The following is a description of a gene set: from publication Rodwell GE, Sonu R, Zahn JM, Lund J, Wilhelmy J, Wang L, Xiao W, Mindrinos M, Crane E, Segal E, Myers BD, Brooks JD, Davis RW, Higgins J, Owen AB, Kim SK (PMID 15562319) Human Gene Set: RODWELL_AGING_KIDNEY_UP studied in species Homo sapiens In this study, we found genes that change expression in the cortex and the medulla of the kidney with age. Some of the genes whose transcripts increase in abundance with age are known to be specifically expressed in immune cells, suggesting that immune surveillance or inflammation increases with age. The age-regulated genes show a similar aging profile in the cortex and the medulla, suggesting a common underlying mechanism for aging. Expression profiles of these age-regulated genes mark not only age, but also the relative health and physiology of the kidney in older individuals. Finally, the set of aging-regulated kidney genes suggests specific mechanisms and pathways that may play a role in kidney degeneration with age. Genes whose expression increases with age in normal kidney., and this is the list of marker genes: PTPN22, MPEG1, ANTXR1, CD38, DOCK2, C7, ST8SIA4, IL4I1, DKK3, COL1A1, PCDHA9, TRAFD1, PGGHG, MGAT1, ASAP1 (NCBI Gene Id 56237), CHRNA3 (cholinergic receptor nicotinic alpha 3 subunit), COMP, TOR4A, SLC40A1, MICALL2, IKBKB, VSIR, MRC1, COL14A1, GIMAP2, LY75, MMP11, MYO1F, FIBIN (NCBI Gene Id 387758), KLF8, TPM1, NICOL1, HAVCR1, TM4SF18, TREX1, FEZ2, SPON2, SLC15A3, CARHSP1, VARS1, DGKQ, ZNF783, DPP3, CD1D, TYROBP, HLA-A, RPS2, TNC, CD53, RAB4B, GGT5, BCL2A1, TXNDC5, IGHA1, CARD8-AS1, ARHGAP45, LAPTM5, MAN2B1, PSMB9, RPS6KA1, RHEX, PTPRC, QPCT, ADGRG1, MOXD1, ARHGAP25, FYB1, GASK1B (NCBI Gene Id 83936), IGHM, TPSAB1, LDLRAP1, SCARNA17, FBN1, VOPP1, IGHV3-23 (immunoglobulin heavy variable 3-23), NFKBIZ, LY6E, CST6, PIK3CG, C1QA, VSNL1, LPCAT1, CD14, CCM2, CALHM6, RIGI, HLA-B (NCBI Gene Id 730410), USP31, ADGRE5, GLIPR2, ARVCF, SVEP1, RPL27, CFB, ARHGDIB, TKT, NNMT, NR2F1, C1QB, CLDN3, TBC1D2B, MYDGF, SLC46A3, PARP14, LST1, HCST, SNORA70, HLA-DRA, JCHAIN (joining chain of multimeric IgA and IgM), POU4F3, PGLS, IFNAR1, NLGN4X, DOK3, NCF1, NUAK1, IGKV1OR2-108, EVI2A, GGTA1, RFTN1, LYSMD2, EHBP1L1, IGLC2, COL8A2, SAMD9L, LTBR, ZCCHC24, PPP1R14B, LASP1, TMEM43, C1QC, C4A, SYMPK, PIGR, GPX8, CXCL16, ZCCHC7, CCR1, SVBP, ITGA1, HIKESHI, SLC6A6, HLA-DRB6, FAU, HLA-DQB1, CXCL1, WDR46, C15orf39, DLGAP1, IL32, COL27A1, PLAAT4, DTX3L, DOCK11, FXYD5, CD69, IGHV3-47, RPS10, PSME2 (NCBI Gene Id 5721), CASP1, IKZF1, RGS1 (regulator of G protein signaling 1), SYTL2, STAB1, TMPRSS4, SLC12A9, ARL4C, CTHRC1, IKBIP, PARP12, KXD1, RAB31, VTCN1, SPTLC3, GMFG, MCAM, KIAA0930, TIMP1, SLC18A2, SULF2, IGKV1D-39, TYMP, HCLS1, KRTCAP2, ITGB2, CLEC4A, LYZ, SSR4, RPL18, CCDC88A, HLA-DRB1, LTB, PGM2L1, MILR1, SHISA5, ALOX5, MARCHF1, TGFBI, RPLP2, PLEKHO1, IGKC, CD47 (NCBI Gene Id 961), IGLL3P (immunoglobulin lambda like polypeptide 3, pseudogene), GABBR1, RAC2, TAP1, CLEC7A, HLA-E, PTPN6, RPS27L, CYRIA, SELPLG, LDLRAD4, TSPAN1, HLA-G, MSR1 (NCBI Gene Id 4481), TAPBP, LYN, ANXA2P3, PRUNE1, PRB1, SPON1, CA5BP1 (carbonic anhydrase 5B pseudogene 1), TMSB10, TMEM243, ISLR, AXL, GNG2, CIMAP1B (NCBI Gene Id 91292), CCND3, VCAM1, CSF1R, FSCN1, ARHGEF6, CHPF2, NKG7, LACC1, NUP62, MALL, CLDN1, GZMA, ARHGAP30, SRGN, IL17B, SHANK2, HTATIP2, GPR61, JAZF1, COL15A1, FN1, IRF9, CALU, CDH6, POLR1D (RNA polymerase I and III subunit D), FZD3, BIRC3, RNF125, PLOD3 (NCBI Gene Id 8985), GPNMB, FNBP1, RBMS3, ZMAT3, SYNGR2, CCL2, ZEB2, PRICKLE1, MYOF, FKBP15, VCAN, HTR7, IRF8, TRIM22, PTPRE, NRXN3, LINC02086 (NCBI Gene Id 105371809), LDLRAD3, TNFAIP2, TAGLN, LCP2, FLT3LG, HLA-DQA1, MIR34AHG, CXCL14, EML3, NUS1, MVP (major vault protein), SERPING1, RARRES1, CELF2, BTN3A3, APRT, APBB1IP, CRIP1, LMF2, ADISSP, IL10RA (NCBI Gene Id 3587), SLC1A3, HLA-F (NCBI Gene Id 3134), COL3A1 (NCBI Gene Id 1281), CORO7, SLFN5, VWCE, TNFRSF11B, CXorf38, CANX, FDXR, CCND2, OSMR (NCBI Gene Id 9180), RPL28, MS4A6A, DRAM1, HLA-DPA1, NFIX, FCER1G (NCBI Gene Id 2207), AEBP1, MYRF, CYBC1, TSPAN18, ITPR3, REEP4, RFLNB, PPP1R14A, MRAS, ADRA2A, RPL35A, ATP8B2, CX3CR1, ARPC1B, RPL13A, GRN, PFN1, RAD54L, CLIC1, C1R, CCL5, LTF, TRIM47, TIMP2, GFRA1, RUBCNL, RPL35, GNB4, TMC6, ARHGAP10, RRP12, NUB1, PPP1R18, MMP7, TESC, RAB3GAP1, IFITM1, BHLHE41, ARHGAP1 (NCBI Gene Id 392), THEMIS2, IGHV3-21, ANTXR2, IRAK1, GABRP, CMTM7, VIM, COL5A1, RPN1, C1S, CXCR4, PXDN (peroxidasin), ADCY10P1, PROM1 (prominin 1), RNF213, HGF, SETD7, RAB33A, STOML1, A2M, COL1A2, RPL18AP16, HLA-DMA, RUNX2, CORO1A, TBCB, C15orf48, PARVG, LAMP1, RAB8B, PDIA4, RAB34 (RAB34, member RAS oncogene family), AMBP, ACTN1, RNF166, RBCK1, INSL3, JAML, GZMK, SLFN11, DEGS1, ACER3 (NCBI Gene Id 55331), NLRC5, BLOC1S4, RTN1, LIG3, ANXA2, GBP5 (NCBI Gene Id 115362), ITM2C, TPM3, WFDC2, INHBA, SLAMF8 (SLAM family member 8), PAM, RPS19 (ribosomal protein S19), SOCS3, CHST15, TBXAS1, ADAM8, AKNA, STK10, TAGLN2, STING1, VASH1, VEGFC, RUNX3, CORO1C (coronin 1C), RGS10, ABCC1, NAPSB, TRBC2, AATF, C1orf216, STAT6, MTHFD1L, ADGRE2, TUBA1A, IRAK2, FAS, CRELD2, CDH11, LEPROT, RPS25, SPARCL1, PREX1, EMP3, PPM1M, ALPK2, PSMB10, SEL1L3, GABRE, UBE2D4, TMED3, RIN3, ASNS, IL17RA, RBP1, SERPINE2, CDO1, NT5E, PALD1, IFNAR2, P4HB, HLA-J, CMTM3, STS, ZFAS1, SNCA, DOK1, LUM, TPBG, ITGB2-AS1, MS4A7, RGS19, PRAG1, LIX1, CALHM2, TFPI, IGHG1, RHOA, FHOD1, PIK3CD, RPL12, MIOS, DPCD, SAMD9, RNASE6, MFGE8, LOXL1, SCN5A, ERICH3 (glutamate rich 3), SAMHD1, TNFRSF25, UBXN1, CLEC10A, ABRACL (NCBI Gene Id 58527), SNHG12, TRBC1, MAP4, CHI3L2, IGKV2D-28, CCN3 (NCBI Gene Id 4856), RASSF5, PSMB8, TCF3 (transcription factor 3), KCND3